Given this list of marker genes TREX1, here is a description of the gene set: Reactome Pathway: Regulation by TREX1 Three prime repair exonuclease 1 (TREX1) is a DNase type III enzyme, which targets and digests unpaired nucleotides on ssDNA and dsDNA ends through a 3'to 5' exonuclease activity (Perrino FW et al. 1994; de Silva U et al. 2007; Lehtinen DA et al. 2008; Fye JM et al 2011). TREX1 is an endoplasmic reticulum (ER)-associated protein, which is anchored to ER membrane via the C-terminal transmembrane domain (Chowdhury D et al. 2006; Richards A et al. 2007; Stetson DB et al. 2009). TREX1 has been implicated in innate immune responses against self (damaged or retrotransposons-derived DNA) and retroviral-derived DNA (Stetson DB et al. 2009; Yan N et al. 2010; Hasan M et al. 2012). TREX1 deficiency in human and mouse cells led to accumulation of cytosolic DNA which resulted in a continual activation of cytosolic DNA-sensors. In addition, cells lacking TREX1 function were less susceptible to infection with different types of RNA viruses (Yan N et al. 2010; Hasan M et al. 2012).Thus, the physiological role of the exonuclease TREX1 is to digest cytosolic host DNA to avoid autoimmunity. Loss-of-function mutations in the gene encoding human TREX1 are associated with several autoimmune diseases (Aicardi-Goutieres syndrome (AGS), familial chilblain lupus (FCL), systemic lupus erythematosus (SLE)) that result in increased levels of interferon and circulating antibodies to DNA (Crow YJ et al. 2006; Rice G et al. 2007; Lee-Kirsch MA et al. 2007). During infection with human immunodeficiency virus (HIV) or other RNA viruses, TREX1 activity may inhibit the innate immune responses by processing viral DNA generated during reverse transcription (Yan N et al. 2010; Hasan M et al. 2012). It's not yet known whether TREX1 is also involved in regulation of host responses to DNA viruses.<p>Detection of nucleic acids is known to launch signaling cascades leading to induction of type I interferons, which in turn orchestrate an immune response that involves the expression of hundreds of interferon-stimulated genes (ISGs). It is interesting to note that interferon(IFN)-independent activation of a subset of ISGs was detected in mouse and human cells lacking functional TREX1 (Hasan M et al. 2012). Hasan et al. have also observed that TREX1-deficiency resulted in an increased lysosomal compartment. Trex1 was found to control mTORC1 activity in mouse embryonic fibroblasts (MEF), which in turn negatively regulates translocation of transcription factor EB (TFEB) to the nucleus thereby controlling lysosomal biogenesis (Hasan M et al. 2012; Roczniak-Ferguson A et al. 2012). The authors linked the altered lysosomal compartment to innate immune responses by suggesting that lysosomal biogenesis (regulated by TFEB and mTORC1) acted upstream of IFN-independent ISG expression (regulated by IRF3 and IRF7) (Hasan M et al. 2012). studied in species Homo sapiens part of: Regulation of innate immune responses to cytosolic DNA